The following is a description of a gene set: Any process that modulates the rate, frequency, or extent of ER to Golgi vesicle-mediated transport, the directed movement of substances from the endoplasmic reticulum (ER) to the Golgi, mediated by COP II vesicles. Small COP II coated vesicles form from the ER and then fuse directly with the cis-Golgi. Larger structures are transported along microtubules to the cis-Golgi. Human Gene Set: GOBP_REGULATION_OF_ER_TO_GOLGI_VESICLE_MEDIATED_TRANSPORT studied in species Homo sapiens, and this is the list of marker genes: SCFD1, RINT1, USE1, GAS1, PGAP1, STX18, LRRK2, YIPF5, SORL1, RNF139, TBC1D20